The following is a description of a gene set: from publication Chen Y, Wang X (PMID 31504780) Human Gene Set: MIR451A studied in species Homo sapiens Genes predicted to be targets of miRBase v22 microRNA hsa-miR-451a in miRDB v6.0 with MirTarget v4 prediction scores > 80 (high confidence targets)., and this is the list of marker genes: CDKN2D, ST8SIA4, CXCL16, OSR1, TRGC1, PSMB8, CUX2